The following is a description of a gene set: Genes up-regulated in T helper cells 15 days post polarization and stimulated with anti-CD3 and anti-CD28: Th1 versus Th17. species: Homo sapiens Serial comparison between Th1 and Th17 tumor-specific cells cultured in vitro and ex vivo after transferred into sublethaly irradiated B6.PL mice. Th17-derived cells acquire Th1-like properties in vivo but maintain a distinct molecular profile. Human Gene Set: GSE26030_TH1_VS_TH17_RESTIMULATED_DAY15_POST_POLARIZATION_UP from publication Muranski P, Borman ZA, Kerkar SP, Klebanoff CA, Ji Y, Sanchez-Perez L, Sukumar M, Reger RN, Yu Z, Kern SJ, Roychoudhuri R, Ferreyra GA, Shen W, Durum SK, Feigenbaum L, Palmer DC, Antony PA, Chan CC, Laurence A, Danner RL, Gattinoni L, Restifo NP (PMID 22177921), and this is the list of marker genes: COLEC12, IFITM2, IMPA2, MMP2, ZBTB37 (NCBI Gene Id 84614), UBE2D1, CDK2, SIRPB2, TCF19, NR2C2, PLXND1, MIS18A, DCAF12, TYMS, SFXN2, IRAK3, PIK3R3, TNS1, LPIN2, LYPLAL1, SORL1, LEPROTL1, RPS4Y1, PRIM2, ALDH1A1, APOBEC3B, GIMAP8 (GTPase, IMAP family member 8), MELK, TANC2, SOD1, SNAP23, PRIM1, H3C11, ZWINT, RRM2, WBP1L, PID1, ANTXR1, CCDC149, TLN2, MAML3, CCNA2, GIMAP2, SPATA6 (NCBI Gene Id 54558), BIRC5 (NCBI Gene Id 332), PEAK1, SLC27A1, ARNT, NUMA1, MARCHF8, ASF1B, MLLT3, PAG1, H2AZ2, FOXP1, ATG7, GLT1D1, SEC22B, RFC5 (NCBI Gene Id 5985), IDH2 (NCBI Gene Id 3418), SYK, FFAR2, TMEM106C, ARAP1, BTBD2, VAV1 (vav guanine nucleotide exchange factor 1), CNOT8 (NCBI Gene Id 9337), ZNF875, RAD51AP1, PRC1, GIMAP1, KIF4A, HEXA-AS1, GIMAP5, MFSD13A, YY2, RACK1, CENPM, SESN1, DSN1, IL13RA1, SLC43A1, ZNF367, RPS6KA5, GIMAP7, GJA5, SELPLG, FLOT1, ELK3, RRM1, STMN1 (stathmin 1), CAMK2G, HJURP, PRKCSH, BRPF3, GRK2, GAPT, PDE2A, POLR1HASP, SP110, SHMT1, PLA2G12A (NCBI Gene Id 81579), POLE, GAS7, SLC2A9, POLR1D, MAPRE2, KDSR, H1-5, MKI67, TMCO6, SIN3A, TPST1, CUX1, GIMAP4, MX2, VNN2, STING1, CRYBB1, EDEM2, PHACTR1, BUB3, C4orf46, GINS2, P2RX7, HMGB2, FAM9B, NIPSNAP3B, CSF3R, LAPTM5, PLXNC1, CRACR2A, CDKN3, CKS2, FPR1, SLC37A4, PARL, RGS10, CPED1, LIMD1, PPP6C, ZDHHC4 (NCBI Gene Id 55146), SKP2, BST1, PILRB, PSMG2, CDCA8, CD101, ADAM28, IFT25 (NCBI Gene Id 51668), METTL9, PCTP (phosphatidylcholine transfer protein), SELL, UBXN11, TMED8, LTA4H, ALOX5, OR4H12P, CNPY3 (canopy FGF signaling regulator 3), H2AC8, FOXO4, PLK1, DUSP10, SVIP, ABI3, H1-2, DAGLB, S100A9, TLE3, DEFB116, ARHGAP35, TPX2, SPARCL1, FAM83D, OAS2, LRRC8D, COQ2, TTLL4, NUP43, CARD6, SLC37A2, IL10RB, SCMH1, CD9, ANKS1A, MFF, LYZ, GRK5, H2BC11, SLAMF6, TMEM119, SEMA4D, AGAP3, RASSF3, CDK1, MCM10, UBXN2A (UBX domain protein 2A), EMP2, TLR7